The following is a description of a gene set: Muscular weakness and atrophy related to loss of the motor neurons of the spinal cord and brainstem. Human Gene Set: HP_SPINAL_MUSCULAR_ATROPHY studied in species Homo sapiens Spinal muscular atrophy, and this is the list of marker genes: VRK1, IGHMBP2 (immunoglobulin mu DNA binding protein 2), FBXO38, TBCE, ATP7A, BICD2, TRIP4, KCNK9, MORC2, TK2, SMN1, CHCHD10, EXOSC8, DYNC1H1, DNAJB2, ASCC1, ASAH1, UBA1, SMN2, VAPB, TRPV4, SIGMAR1, PLEKHG5, AHDC1